The following is a description of a gene set: Human Gene Set: GOMF_SYNTAXIN_BINDING Binding to a syntaxin, a SNAP receptor involved in the docking of synaptic vesicles at the presynaptic zone of a synapse. studied in species Homo sapiens, and this is the list of marker genes: DOC2B, STX6, VPS54, SYT1, STX8, TXLNG, SYT5, HECTD3, UNC13A, ABL1, ABCA1, STXBP3, SNAP23, SCFD1 (NCBI Gene Id 51681), DAPK1, SNAP29, PRRT2, VPS52, TMED10, NSF, STX7, CPLX4, VAMP1, VPS18, SLC6A4, VAMP2, UNC13C (NCBI Gene Id 440279), CPLX1, STXBP5, NAPB, TXLNGY, SNAP25, STXBP4, TXLNA, CPLX3, SNAP47, BAIAP3, PTPN2, TXLNB, CPLX2, CACNA1A, VAMP3, GOLGA2, STX10, VPS11, TMED9, UNC13B, STXBP1 (NCBI Gene Id 6812), STXBP2, RAB11A, SYT6, NAPA, STXBP5L, NAPG, SYT7, TPCN1 (NCBI Gene Id 56236), SNPH, LRRK2, VAMP8, STX16, BLOC1S6